The following is a description of a gene set: species: Homo sapiens A signaling process that controls cell cycle progression in response to changes in DNA structure by monitoring the integrity of the DNA. The DNA integrity checkpoint begins with detection of DNA damage, defects in DNA structure or DNA replication, and progresses through signal transduction and ends with cell cycle effector processes. Human Gene Set: GOBP_DNA_INTEGRITY_CHECKPOINT_SIGNALING, and this is the list of marker genes: INTS7, NOP53, CHEK1, FBXO6, CLOCK, STK38, IER3, MRNIP, CUL4A, TREX1, MRE11, SDE2, RPS27L, TELO2, TIPIN, BLM, TTI1, TAOK2, MAPK14, CAMSAP3, SYF2, XPC, UFL1, E2F1, RHNO1, ATR, TIPRL, DTL, FEM1B, DONSON, MBTPS1, FBXO4 (NCBI Gene Id 55087), STK33, RAD9A, HUS1, PRKDC, DNA2, MSH2, EME1, ERCC6, USP28, CCAR2 (NCBI Gene Id 57805), BARD1, BRSK1, RAD51, PRPF19, RPA4, TRIAP1 (TP53 regulated inhibitor of apoptosis 1), NEK11, CRY1, BRCA2, CEP63, ATF2, CDC14B, PARP9, TRIM39, RFWD3, TOPBP1, CDK1, TP53, CLSPN, TAOK1, BRCC3, CHEK2, ABRAXAS1, BABAM1, FZR1, RAD17, GNB1L, MDC1, FANCD2, FOXN3, TIMELESS, NBN, TTI2, DOT1L, ATM, MUC1, H2AX, DGKZ, MAP3K20, ATRIP, HUS1B (NCBI Gene Id 135458), ORC1, MBTPS2, RAD1, FBXO31, NAE1, RPA2, TP53BP1, FOXO4, CDT1, WDR76, CDC5L, CCND1, WAC, RNASEH2B, BRIP1, EME2, CDC6, CDK5RAP3, PLK1 (polo like kinase 1), CDKN1A, UIMC1, BRD4, ZNF830, HINFP (NCBI Gene Id 25988), TAOK3, EIF2AK4, RINT1, CDC45, TICRR, BRCA1, PTPN11, GIGYF2, DTX3L, BABAM2, LYN (NCBI Gene Id 4067), SETMAR, ETAA1, PPP1R10, MUS81, CDK2, RAD9B